Given this list of marker genes Lmna, Lpin3, Nup155, Cnep1r1, Ndc1, Nup88, Rbm39, Banf1, Nup35, Emd, Nup43, Cdk1, Nup42 (nucleoporin 42), Nup98, Rae1, Ranbp2, Nup93, Vrk1, Nup153, Nup58, Ccnb2, Nup62, Prkcb, Nup107, Nup214, Nup54, Lpin2, Ccnb1, Ctdnep1, Nup85, Vrk2, Seh1l (SEH1-like (S. cerevisiae), Nup37, Nup205, Nup133, Nup160, Tpr, Lmnb1, Nup210, Nup188, Aaas, Sec13, Plk1, Pom121 (NCBI Gene Id 97245), Nup50, Nek9, here is a description of the gene set: Nuclear Envelope Breakdown studied in species Mus musculus Mouse Gene Set: REACTOME_NUCLEAR_ENVELOPE_BREAKDOWN